The following is a description of a gene set: from publication Hu T, Gibson DP, Carr GJ, Torontali SM, Tiesman JP, Chaney JG, Aardema MJ (PMID 15120960) studied in species Mus musculus Mouse Gene Set: HU_GENOTOXIC_DAMAGE_24HR During the safety evaluation process of new drugs and chemicals, a battery of genotoxicity tests is conducted starting with in vitro genotoxicity assays. Obtaining positive results in in vitro genotoxicity tests is not uncommon. Follow-up studies to determine the biological relevance of positive genotoxicity results are costly, time consuming, and utilize animals. More efficient methods, especially for identifying a putative mode of action like an indirect mechanism of genotoxicity (where DNA molecules are not the initial primary targets), would greatly improve the risk assessment for genotoxins. To this end, we are participating in an International Life Sciences Institute (ILSI) project involving studies of gene expression changes caused by model genotoxins. The purpose of the work is to evaluate gene expression tools in general, and specifically for discriminating genotoxins that are direct-acting from indirect-acting. Our lab has evaluated gene expression changes as well as micronuclei (MN) in L5178Y TK(+/-) mouse lymphoma cells treated with six compounds. Direct-acting genotoxins (where DNA is the initial primary target) that were evaluated included the DNA crosslinking agents, mitomycin C (MMC) and cisplatin (CIS), and an alkylating agent, methyl methanesulfonate (MMS). Indirect-acting genotoxins included hydroxyurea (HU), a ribonucleotide reductase inhibitor, taxol (TXL), a microtubule inhibitor, and etoposide (ETOP), a DNA topoisomerase II inhibitor. Microarray gene expression analysis was conducted using Affymetrix mouse oligonucleotide arrays on RNA samples derived from cells which were harvested immediately after the 4 h chemical treatment, and 20 h after the 4 h chemical treatment. The evaluation of these experimental results yields evidence of differentially regulated genes at both 4 and 24 h time points that appear to have discriminating power for direct versus indirect genotoxins, and therefore may serve as a fingerprint for classifying chemicals when their mechanism of action is unknown. Genes most consistently regulated at 24 h by all six genotoxins tested: cisplatin, methyl methanesulfonate, mitomycin C, taxol, hydroxyurea and etoposide., and this is the list of marker genes: Serpinb9, Batf3, Nabp1, Tox4, Ddr1, Imp3, Cdh15, Slc7a5, Gzmb, Gm15421, Jund, Dnaja1, H2ac4, Naa38, Atf4, Ifi202b, Eef2, Eif1b, Slc1a4, Rpl10a, Mthfd2, Cd7, Isg15, Aldh18a1, Banf1, Casp1, Snhg6, Tubb2a, Wdr83os, Rpl3, Ubap2l, Iars1, Eif4ebp1, Bag3, Tmod3, Hmgb3, H2ax, Norad, Herpud1